Given this list of marker genes GRID2, SERPINE2, KIF14, GBA1, HERC1, OPHN1, SLC25A46, SMO, GLI1, GLI2, AGTPBP1, RORA, WNT7A (Wnt family member 7A), TUBA1A, FOXP2, WHRN, PTPN11, LHX1, COMT, NRXN1, DLL1, LHX5, ZNF365, CEND1, TRNP1, CBLN1, TTC21B, CDK5, KNDC1, ATP7A, TTLL1, COQ8B, MAP2K1, LDB1, SKOR2, SPTBN2, PROX1, FAIM2, here is a description of the gene set: Human Gene Set: GOBP_CEREBELLAR_CORTEX_MORPHOGENESIS The process in which the anatomical structure of the cranial nerves are generated and organized. The cerebellar cortex is a thin mantle of gray matter that covers the surface of each cerebral hemisphere. It has a characteristic morphology with convolutions (gyri) and crevices (sulci) that have specific functions. Six layers of nerve cells and the nerve pathways that connect them comprise the cerebellar cortex. Together, these regions are responsible for the processes of conscious thought, perception, emotion and memory as well as advanced motor function. studied in species Homo sapiens